The following is a description of a gene set: species: Homo sapiens Human Gene Set: GOBP_RESPONSE_TO_VITAMIN Any process that results in a change in state or activity of a cell or an organism (in terms of movement, secretion, enzyme production, gene expression, etc.) as a result of a vitamin stimulus., and this is the list of marker genes: PDX1, GAS6, KANK2, TSPO, NNT, SNW1, F5, GSTP1, CASR, ABCB1, FOLR2, FOLR1, SPP1, GDAP1, SLC34A1, TRIM25, RELA, PPARD, TRIM24 (tripartite motif containing 24), FES, CXCL10, POSTN, SCAP, SOD2, TNC, F7, EPO, EEF2, CCND1, CYP1A1, MN1, PHEX, ABCA1, SFRP1, CD4, LEP (leptin), ITGA2, BMP7, HLCS, MIR125B1, RXRA, BECN1, ALPL, SNAI2, NCOA3, MTHFR, MDM2, CYP24A1, GPX1, DNMT3A, LIPA, PTH, RARA, ENSG00000274276 (cystathionine-beta-synthase like), KYNU, CEBPA, TGFB1, GATA4, CYP26A1, STC1, FGF23, CAT, RXRB, OTC, ALDH1A2, STC2, PIM1, COL1A1, KL, CDKN2D, LRAT (NCBI Gene Id 9227), BCHE, MAP1B, CYP27B1, CD40, CYP26B1, MT-CYB, ALAD (aminolevulinate dehydratase), VDR, TYR, CBS, ASCL1, MED1, NFKBIZ, TPCN2 (NCBI Gene Id 219931), GPRIN3, BGLAP, PENK, AQP3